Given this list of marker genes ZNF827, ZEB2, MYB, SLC4A2, GPM6B, HEY1, UBE2R2, SULF2, CNMD, MTUS1, SDHAF2, MYOZ3, IKZF2, TAC1, FAM91A1, CXADR, NFAT5, KRT23, USP3, SLC39A13, INPP4B, ELAVL4, LEMD1, EMX2, CDC14A, IL22, CPSF7, CHRDL1, SRPK2, SAMD11, NRXN1, MYL2 (myosin light chain 2), SPMIP6, WNT2, PTCHD4, LRRN1, PDZRN4, FOXP2, MYO18B, GTPBP2, NOL4, CASQ2, CDH20, TSPAN2, ST7, MAP2, TMOD4, MGAT4C, JAKMIP2, RTL9, ZHX2 (NCBI Gene Id 22882), FGF10, SLC6A4, FAR2, CELF4, SMARCA2, SLC43A3, OR10J1, GTPBP1, ELK3, CDK5, NUAK2, FAM53C, PDHA2, here is a description of the gene set: Comprehensive identification of all functional elements encoded in the human genome is a fundamental need in biomedical research. Here, we present a comparative analysis of the human, mouse, rat and dog genomes to create a systematic catalogue of common regulatory motifs in promoters and 3' untranslated regions (3' UTRs). The promoter analysis yields 174 candidate motifs, including most previously known transcription-factor binding sites and 105 new motifs. The 3'-UTR analysis yields 106 motifs likely to be involved in post-transcriptional regulation. Nearly one-half are associated with microRNAs (miRNAs), leading to the discovery of many new miRNA genes and their likely target genes. Our results suggest that previous estimates of the number of human miRNA genes were low, and that miRNAs regulate at least 20% of human genes. The overall results provide a systematic view of gene regulation in the human, which will be refined as additional mammalian genomes become available. Human Gene Set: RNTCANNRNNYNATTW_UNKNOWN studied in species Homo sapiens from publication Xie X, Lu J, Kulbokas EJ, Golub TR, Mootha V, Lindblad-Toh K, Lander ES, Kellis M (PMID 15735639) Genes having at least one occurrence of the highly conserved motif M122 RNTCANNRNNYNATTW in the regions spanning 4 kb centered on their transcription starting sites. The motif does not match any known transcription factor binding site.